Given this list of marker genes Pot1a, Stn1, Terf2ip, Terb1, Ten1, Terf2, Rif1, Terf1, Pot1b, Tinf2, Acd, Ctc1, here is a description of the gene set: A complex of DNA and protein that seals the end of a chromosome. The telomeric repeat DNA consists of simple tandemly repeated sequences specific for each species. Typically one strand is G-rich and the other C-rich. The G-rich strand forms a 3'-terminal overhang, the length of which varies with species. The single strand overhang is bound by a variety of proteins, including telomere capping proteins that bind to the single-stranded DNA and seal the telomeric loop. Mouse Gene Set: GOCC_CHROMOSOME_TELOMERIC_REPEAT_REGION species: Mus musculus